Given this list of marker genes PARP9, UBE2L6, APOL6, GBP2, IRF1, INPP1, HAPLN3, TRIM69, GBP4, EPSTI1, FBXO6, GBP5, STAT1, GBP1, here is a description of the gene set: BACKGROUND: Vaccine development for influenza A/H5N1 is an important public health priority, but H5N1 vaccines are less immunogenic than seasonal influenza vaccines. Adjuvant System 03 (AS03) markedly enhances immune responses to H5N1 vaccine antigens, but the underlying molecular mechanisms are incompletely understood. OBJECTIVE: We compared the safety (primary endpoint), immunogenicity (secondary), gene expression (tertiary) and cytokine responses (exploratory) between AS03-adjuvanted and unadjuvanted inactivated split-virus H5N1 influenza vaccines. In a double-blinded clinical trial, we randomized twenty adults aged 18-49 to receive two doses of either AS03-adjuvanted (n = 10) or unadjuvanted (n = 10) H5N1 vaccine 28 days apart. We used a systems biology approach to characterize and correlate changes in serum cytokines, antibody titers, and gene expression levels in six immune cell types at 1, 3, 7, and 28 days after the first vaccination. RESULTS: Both vaccines were well-tolerated. Nine of 10 subjects in the adjuvanted group and 0/10 in the unadjuvanted group exhibited seroprotection (hemagglutination inhibition antibody titer > 1:40) at day 56. Within 24 hours of AS03-adjuvanted vaccination, increased serum levels of IL-6 and IP-10 were noted. Interferon signaling and antigen processing and presentation-related gene responses were induced in dendritic cells, monocytes, and neutrophils. Upregulation of MHC class II antigen presentation-related genes was seen in neutrophils. Three days after AS03-adjuvanted vaccine, upregulation of genes involved in cell cycle and division was detected in NK cells and correlated with serum levels of IP-10. Early upregulation of interferon signaling-related genes was also found to predict seroprotection 56 days after first vaccination. CONCLUSIONS: Using this cell-based systems approach, novel mechanisms of action for AS03-adjuvanted pandemic influenza vaccination were observed. TRIAL: ClinicalTrials.gov NCT01573312. from publication Howard LM, Hoek KL, Goll JB, Samir P, Galassie A, Allos TM, Niu X, Gordy LE, Creech CB, Prasad N, Jensen TL, Hill H, Levy SE, Joyce S, Link AJ, Edwards KM (PMID 28099485) Genes up-regulated in B cell 1d vs 0d in adults (18-49) after exposure to inactivated monovalent influenza A/Indonesia/05/2005 H5N1 split-virus vaccine, time point 1D, administered i.m. Human Gene Set: HOWARD_B_CELL_INACT_MONOV_INFLUENZA_A_INDONESIA_05_2005_H5N1_AGE_18_49YO_1DY_UP species: Homo sapiens